The following is a description of a gene set: studied in species Homo sapiens Transcriptional profiling of NKAES-derived NK cells after 7 days of culture compared to primary human NK cells and NK cells stimulated by low or high dose IL2 after 7 days of culture. from publication Fujisaki H, Kakuda H, Shimasaki N, Imai C, Ma J, Lockey T, Eldridge P, Leung WH, Campana D (PMID 19383914) Human Gene Set: GSE12198_CTRL_VS_LOW_IL2_STIM_NK_CELL_UP Genes up-regulated in NK cells: primary versus stimulated by low dose of IL2., and this is the list of marker genes: GNG2, H1-4, AHCTF1, ARHGAP1, TDO2, NFAM1, QRICH1, EGR1, RIOK3, ZMYND8, SLC25A28, MLLT10, OPN4, PPOX, STK39, PLIN2, STAT5B, CEP70, MED4, RNF112, SEMA4F, B2M, ACVR1B, CAPN2, RDM1, CD8B, ERRFI1, PLAAT3, SERPINB6, IQSEC1, RBM12, NDRG1, DRC1, MAP7, MOB2, P4HA2, GYPC, MCOLN3, METTL27, EHHADH, HINT3, SFI1, HIBCH, SRCAP, TRPV2, PARD6G, UNC93B1, S100A11, CDCA3, IDNK, ZSCAN21, ICAM2, CENPQ, WDHD1, SPICE1, GATAD2B, PIK3R1, PCSK7, AP3B1, CRIM1, TMCO6, NTRK3, PI4K2A, CUTA, PCNX3, PCNX1, SH3BGRL, MFSD10, SUCO, C16orf87, PPM1B, PPP1R18, ZNF521, RGR, TXK, CRIPT, MSN, AP3D1, NT5C3A, ITPK1, SAFB, OMG, MBD1, CA6, VPS13C, DGKE, ALDH6A1, DIAPH1, PXMP4, RHOA, MARVELD1, SPO11, SLC35F6, DMBT1, TET1, PAN2, FAM120B, TMEM131, HMBOX1, PCCB, TTC7B, KDM3B, SRRT, MTMR4 (myotubularin related protein 4), TEX9, NAAA, PPIC, IRAK4, TSTD1, TTC13, HIVEP1, MSRB1, IDH2, KDR, ISG20 (NCBI Gene Id 3669), PIWIL1, TAPBP, FNTB, MPZL2, FGF11, RAMAC, XRN1, ACTR1A, NAV2, RLF, CD53, RPS6KA2, MKRN2, NRF1, PTPN23, PIP4P2, WAC (WW domain containing adaptor with coiled-coil), RPLP1, GZMA, TAFAZZIN, SUOX, KATNA1, TLR6 (NCBI Gene Id 10333), ACTN2, TESK2, EML3, TAX1BP1, WNT5B, ICAM1 (NCBI Gene Id 3383), FMO5, SAT1, CMTR1, SYK, ABHD15, CDH8, TMUB2, AP4B1, ATN1, LMO2, CCDC92, MSRA, PLAC8, CEP57L1, RELA, AGRP, FBXO25, ARMCX1, MAPRE3, TCF19, CA2, DIAPH2, KANSL1, ESYT1, FASLG, ART4, CFAP141, PTBP3, ARIH2, DYNLT1, SMC1A, MORF4L2, SECISBP2, PGAP6, MTHFR, LIMD1, LPIN1, INAVA, ATP13A2, PRKRA, NUDT14, RNF123, TMEM176A, AP1M2, PDCD10, ZMYM1, KLF3, ZNF18, CPEB4, FHIT, GIMAP1, ATG16L1, ARL4A, TBL1XR1, MVD, TPST2